Given this list of marker genes CD1B, CD1D (CD1d molecule), TLR10, TLR2, CD1E, CD1C, LBP, TLR1, TLR6, CD1A, here is a description of the gene set: Binding to a lipopeptide, any of a group of organic compounds comprising two or more amino acids linked by peptide bonds and containing a nonprotein group consisting of a lipid or lipids. Human Gene Set: GOMF_LIPOPEPTIDE_BINDING species: Homo sapiens